The following is a description of a gene set: Human Gene Set: MIR548S studied in species Homo sapiens Genes predicted to be targets of miRBase v22 microRNA hsa-miR-548s in miRDB v6.0 with MirTarget v4 prediction scores > 80 (high confidence targets). from publication Chen Y, Wang X (PMID 31504780), and this is the list of marker genes: SLC30A5, ZNF318 (NCBI Gene Id 24149), AKAP12, ZC3H12C, NIPAL1, TNFAIP1, ECHDC1, RBL1, CBFA2T2, TFRC, ZNF326, YIPF4, MRAP2, HCRTR1, CNOT10, CLIP1, TES, TNS4, NLN, OSR1 (NCBI Gene Id 4955), MED18, ZDHHC21, SLC35F3, KANSL1, ANKUB1, EIF4EBP2, DHX15, PIGA, RYK, KLF12, C1orf94, CNOT1, MTCL2, EEF1A1, TULP4, PCDHB14, DPY19L3, N4BP2L1, TTPAL, DIP2A, BPTF, GPRC5B (NCBI Gene Id 51704), BACH1 (BTB domain and CNC homolog 1), SERF2, MARCKSL1, AVEN, ESYT2, HMGA2, DSTN, RRAS2, KIAA1549, HSPBAP1, BIRC6, CRTAP, HOMER1, MMP24, ARID3B, SCARF2, COA3, ACAP2, ADGRD1, NAA15, EDA2R, SDC3, POP1, RBMX, PRKAR2B (NCBI Gene Id 5577), FBLN1, ATP11A, GNAZ, SCN2A, MMAA, ATXN1, JAM3, C1orf21, PAQR3, ABLIM3, ACTR8, VPS26A, VXN, CREB1, SATB1, CCER1, SBSPON, SOX5, EBPL, ZNF423, ANAPC16, DDX3Y, LOXL1, P4HB, KCNG3, TEX35, ZNF678, KCNJ15, CYSTM1, EVA1A, OAT, ANKFY1, CLN5, NIPAL4, TSHZ2, GALNT15, POLR1B, ANKIB1, CSDE1, CIMIP2B, TMEM51 (transmembrane protein 51), NFAT5, LSM12, PPP6R3, DGKK, MMRN2, CYP20A1, PTPN11, CPSF6, TLL2, SELENOT, DGKE, DIP2B, PCNX4, SMC3, NDUFA2, NTRK2, FOXG1, ZNF576, MB21D2, RPL15, PRKCE, STRBP, SCG5